The following is a description of a gene set: Human Gene Set: PID_ERBB1_DOWNSTREAM_PATHWAY from publication Schaefer CF, Anthony K, Krupa S, Buchoff J, Day M, Hannay T, Buetow KH (PMID 18832364) ErbB1 downstream signaling studied in species Homo sapiens, and this is the list of marker genes: AKT1, PRKCD, MLST8, ABI1, ARPC5, ARPC4, BAD, IQGAP1, RAC1, SRF, MAP2K1 (mitogen-activated protein kinase kinase 1), PRKCA, CAPN2, HRAS, MAPKAP1, ACTR2, YWHAH, SFN, MYL11, PPP5C, MEF2C, DUSP6, EGF, PPP2R1A, VAV2, CHN2, BCL2L1, SRC, FOS, YWHAB, SH2D2A, STAT3, MAPK1, BRK1, RAF1, MAP3K2, YWHAE, PIK3R1, MAP2K2, NCKAP1, SMAD1, F2RL2, PLD2, CYFIP2, GRB2, MAP2K4, ARPC3, USP6NL, NRAS, EGFR, DIAPH3, JUN, YWHAQ, RPS6KA5, KSR1, PLD1, ARF4, WASL, BAIAP2, CREB1, WASF2, RPS6KA4, PIK3CB, SOS1, ATF2, MTOR, PIK3CD, MAPK8, MAP3K1, EPS8, RICTOR (RPTOR independent companion of MTOR complex 2), PIK3R3, RPS6, MAPK9, PIK3R2, MAP2K5, ZFP36, ARPC2, DUSP1, ARPC1B, MAPK7, MAPK3, CDC42, KRAS, YWHAZ, ATF1 (NCBI Gene Id 466), EGR1, RALA, RIN1 (Ras and Rab interactor 1), RPS6KA3, ACTR3, SLC9A1, RAB5A, GAB1, PRKCZ, PEBP1, YWHAG, RALGDS, PDPK1, BRAF, STAT1, PPP2R2A, PIK3CA, PPP2CA, ELK1